Given this list of marker genes Alb, Casp1, Ptger3, Ptger4 (NCBI Gene Id 19219), Ghrhr, Adora2a, Mtnr1b, Ghrh, Npy2r, Uts2, Uts2r, Pmch, Ghrl, here is a description of the gene set: Mouse Gene Set: GOBP_POSITIVE_REGULATION_OF_CIRCADIAN_SLEEP_WAKE_CYCLE_SLEEP studied in species Mus musculus Any process that activates or increases the duration or quality of sleep, a readily reversible state of reduced awareness and metabolic activity that occurs periodically in many animals.